The following is a description of a gene set: studied in species Mus musculus Enables the transfer of a solute or solutes from one side of a membrane to the other according to the reaction: solute(out) + cation(out) = solute(in) + cation(in). Mouse Gene Set: GOMF_SOLUTE_MONOATOMIC_CATION_SYMPORTER_ACTIVITY, and this is the list of marker genes: Slc36a1, Gm5134, Slc6a8, Slc12a3, Slc5a2, Slc5a4a, Slc5a3, Slc6a7, Slc15a1, Slc6a3, Slc5a11, Slc4a5, Slc17a6 (NCBI Gene Id 73055), Slc4a10 (NCBI Gene Id 94229), Slc39a12, Slc6a14, Slc6a20b, Slc12a1, Slc17a8 (NCBI Gene Id 216227), Slc1a6, Slc28a3, Slc12a7, Slc39a4, Slc23a2, Slc13a2, Slc2a4, Slc6a12, Slc16a3, Slc36a2, Ctns, Slc36a3, Slc10a5, Slc5a10, Slc22a3, Slc45a2, Slc6a2, Slc46a1, Slc1a2 (NCBI Gene Id 98863), Slc10a3, Slc5a9, Slc39a14, Slc10a2, Slc20a2, Slc10a1, Slc28a2b, Slc13a5, Slc12a2, Slc6a1, Slc6a4, Slc6a11, Slc6a9, Slc13a3, Slc45a3 (NCBI Gene Id 98605), Slc17a7, Slc12a6, Slc38a3, Slc39a10, Slc25a22 (NCBI Gene Id 68267), Slc20a1, Slc29a1, Slc12a8, Slc39a6, Slc10a4-ps, Slc18a1, Slc1a1, Slc28a1, Slc5a7, Slc16a1, Slc38a4, Slc39a8, Slc15a4, Slc13a4, Slc34a2, Slc1a7, Slc34a3, Slc45a1, Slc10a6, Slc38a2 (NCBI Gene Id 67760), Slc4a8, Slc5a12, Slc12a9, Slc5a1, Slc12a5, Slc15a2, Slc5a5, Slc4a7, Slc45a4, Slc5a8, Slc6a5, Slc38a7, Slc4a4, Slc38a1, Slc22a1, Slc5a6, Slc11a2, Slc25a18, Slc23a1, Slc6a15 (NCBI Gene Id 319850), Slc2a13, Slc6a6, Slc4a9, Slc18a2, Slc12a4, Slc13a1, Slc25a3, Slc28a2, Slc39a5, Slc10a4, Slc6a18, Slc1a3, Slc6a13, Slc34a1, Slc6a20a, Slc5a4b, Mfsd2a (MFSD2 lysolipid transporter A, lysophospholipid)